The following is a description of a gene set: Human Gene Set: MODULE_465 Genes in the cancer module 465. studied in species Homo sapiens, and this is the list of marker genes: CRISP1, SYN3, GTF2H2, CD24, RGS4, SLC27A4, ALDH3B2, ATL2, SRXN1, PDE3B, MIR4453HG, DUSP6, C5AR1, BAZ1B, C5, FPR1